Given this list of marker genes Spink2, Fsip1, Actl9 (NCBI Gene Id 69481), Acrbp, Garin1a, Ccdc42, Rab1a, Actl7a, Ccdc136 (NCBI Gene Id 70878), Tbpl1, Cylc1, Tmf1, Zpbp, Ccdc38, Nectin2, Tbc1d20, Agfg2, Mfsd14a, Garin1b, Sppl2c, Cylc2, Dcaf17, Pln, Pfn4, Spaca1, AU040320, Pla2g3, Vps13b, Sox30, Sec23ip, Eqtn, Poc1b, Zpbp2, Tmprss12, Slc9a8, Izumo3, Rfx2, Agfg1, Pdcl2, Chn2, Fam209, Garin3, Pafah1b1, here is a description of the gene set: Mouse Gene Set: GOBP_ACROSOME_ASSEMBLY The formation of the acrosome from the spermatid Golgi. species: Mus musculus